The following is a description of a gene set: Abnormal decrease of T cell proliferation in response to anti-CD3/28 stimulation. This is commonly measured through intracellular expression of Ki67, decreasing surface expression of carboxyfluorescein diacetate (CFSE), or 3H-thymidine incorporation. Length of incubation and strength of stimulation may vary between laboratories. Decreased anti-CD3/28-induced T-cell proliferation species: Homo sapiens Human Gene Set: HP_DECREASED_ANTI_CD3_28_INDUCED_T_CELL_PROLIFERATION, and this is the list of marker genes: KNSTRN, MALT1, MCM10, STAT1 (NCBI Gene Id 6772), JAK3, SLF2, IL2RA, TNFRSF9, RAC2, PIK3CD